The following is a description of a gene set: studied in species Homo sapiens Total ophthalmoplegia Paralysis of both the extrinsic and intrinsic ocular muscles. Human Gene Set: HP_TOTAL_OPHTHALMOPLEGIA, and this is the list of marker genes: NTNG1, SMC1A, POLG, GABBR2, TMEM67, GRIN1, MECP2, CDKL5